Given this list of marker genes MAP2K7, CDK5, DAB1, PAFAH1B1, ITGA3 (NCBI Gene Id 4454), PIK3R1, VLDLR, GRIN2A, ITGB1, NCK2, CDK5R1, PIK3CA, RAPGEF1, FYN, LRPAP1, LRP8, MAP3K11, GSK3B, AKT1, CBL, MAPT, GRIN2B, ARHGEF2, RELN, MAP1B, MAPK8, RAP1A, CRKL, here is a description of the gene set: Reelin signaling pathway Human Gene Set: PID_REELIN_PATHWAY studied in species Homo sapiens from publication Schaefer CF, Anthony K, Krupa S, Buchoff J, Day M, Hannay T, Buetow KH (PMID 18832364)